Given this list of marker genes HSPG2 (NCBI Gene Id 7796), ZNF444, SIPA1L2, HSPA5, IDO1, POLR2F, SCX, IL4, MYCBP, GPRASP1, NUTF2, LAMA4, MORC4, GBA2, TBC1D24, NT5DC3, SMAD2, THBS3, TULP3, SNRNP25, SLC22A5, ZNHIT3, HPD, MAST2, UBE2N, SRMS, UBE2K, MC1R, RYK, LRP5, IRF8, OR6A2, MBD4, MAPKAPK5, PLAU, GJA1, PIP4K2C, TIMM8A, HOXC5, SEMA6C (semaphorin 6C), HTR3A, RUNX1T1, TUSC2, MPP3, MEOX1, HLA-DOB (major histocompatibility complex, class II, DO beta), GZMM, RENBP, KLHL21, PPIH, ZNF23, TBRG4, MYL6B, GAMT, GCH1, MYO10, SAA4, PENK, MIF (NCBI Gene Id 4282), RPA3, SCN10A, PHLDA2, SLC38A4, PDGFRB, LDB1, IFIT2, MARK4, H1-4, KLF4, EMC4, GJC1, HTR2C, TNFRSF1A, TMEM14C, SH3BGR, SIGLEC1, IGF1, UFD1, NEDD8, RACK1, PTP4A2, TALDO1, PKP1, WDR46, IL1R1, EMC3, IFIT3, MC5R, ODF1, PRAF2, IL1RAP, PSTPIP2, RNASEH1, AFG2A, NUDT5, HCRT, MRPS14, ROCK2, KTN1, OGFOD2, NOP58, EMC2, TMT1A, HPN, MRTO4, TEAD4, REEP6, USP5, PRSS58, SYNGR2, SLC22A6, TEX2, PPP6C, POLR2H, MSRB1, PLG, INPP1, NTN1, INHBC, GJA4, SHF, IQGAP3, TYSND1, NKAIN1, MRPS25 (NCBI Gene Id 64950), NCK2, H3C7, KCNK3, METTL18, GPN3, RFK, KRT6A, NFU1, GCDH, PCDH7, NACC2, TSFM, UTP3, TEKT2, MRPL45, SRSF9, NPM3, SLC6A6, NRCAM, SDSL, P3H3, IFNB1, KCNE1, IL5, MCM5, MRPL38, HOXB7, POU3F3, LAMA5, SYT7, MOGAT2, TIGD5, NUP62, POP4, MYH14, LACTB2, RAX, POLR2J, SLC22A12, SAR1A, GPR37, EEF1AKMT1, MEST, GABARAPL1, TFEB, RYR3, VAX2, GATA1, MKNK1, PRR15, HPGD, SEMA3F, PKHD1, TMEM50B, VEGFA, SFTPC, IL1RN, SLC20A1, PEMT, PBX3, MRPL13, MRPL3, PSMC1, TMEM30B, LRPPRC, GRPEL2, PRMT1, SNX21, PNMT, GRIA3, MRPS7, NQO1, SCAMP1, IRF2BP1, here is a description of the gene set: studied in species Homo sapiens Human Gene Set: GSE15930_STIM_VS_STIM_AND_TRICHOSTATINA_72H_CD8_T_CELL_DN Differentiation of naive CD8 T cells into cytotoxic effector cells requires three distinct signals- antigen (signal 1), costimulation -B7-1 (signal 2) and cytokine, either interleukin-12 or interferon-a/b (signal 3). Interaction of naive CD8 T cells with antigen and B7-1 programs cell division and proliferation whereas the presence of cytokines- IL-12 or IFNa/b promote survival, differentiation and memory establishment. In the absence of signal 3, the cells interacting with antigen/B7-1 undergo tolerance induction. The objective of this study was to elucidate the mechanisms how the provision of signal 3 promotes differentiation and averts tolerance induction in CD8 T cells. Trichostatin A is a pharmacological agent that inhibits histone deacetylase activity, hence regulating chromatin structure and gene expression and differentiation in many cell types. Gene signature profiles of IL-12, IFNa/b and trichostatin A stimulated cells were compared to elucidate the molecular mechanisms of gene regulation. Oligonucleotide microarray analysis is carried out to determine the extent and molecular nature of the CD8 T cell differentiation program induced by IL-12 or IFNa/b in concert with antigen and B7-1 signal. Genes down-regulated in comparison of unstimulated CD8 T cells at 72 h versus CD8 T cells at 72 h after treatment with trichostatin A (TSA). from publication Agarwal P, Raghavan A, Nandiwada SL, Curtsinger JM, Bohjanen PR, Mueller DL, Mescher MF (PMID 19592655)